Given this list of marker genes CHRNA7, DPYD (NCBI Gene Id 1806), SC5D, ASNS, PDE4D, SPEN (spen family transcriptional repressor), PAX3 (NCBI Gene Id 5077), PRKACB, ZEB2, CCDC8, CHD5, SYT1, BCL11A, KCNJ6, RFX7 (regulatory factor X7), CASP2, PPP3CA, CSGALNACT1, PCGF2, MED25, OBSL1, WDR26, AUTS2, FLCN, PGM2L1, BICRA, ZNF462, MADD, here is a description of the gene set: Prominent nasal tip Human Gene Set: HP_PROMINENT_NASAL_TIP studied in species Homo sapiens